The following is a description of a gene set: Human Gene Set: HE_LIM_SUN_FETAL_LUNG_C7_FGFBP2_POS_NEURAL_PROGENITOR_CELL species: Homo sapiens FGFBP2+ Neural progenitor from publication He P, Lim K, Sun D, Pett JP, Jeng Q, Polanski K, Dong Z, Bolt L, Richardson L, Mamanova L, Dabrowska M, Wilbrey-Clark A, Madissoon E, Tuong ZK, Dann E, Suo C, Goh I, Yoshida M, Nikolić MZ, Janes SM, He X, Barker RA, Teichmann SA, Marioni JC, Meyer KB, Rawlins EL (PMID 36493756), and this is the list of marker genes: AQP1, RIMS3, ANKHD1, PSMB8, SCGB3A2, VIP, ADM (NCBI Gene Id 133), VWDE, MIRLET7BHG, RNASE1, CCSER1, MAP3K5, WFIKKN2, ARHGAP18, NKD1, DGKB, TMEM100, WDR27, ERV3-1, NPB, FGFBP2, LAMA5, DDC, PLCD4, EGLN3, FRMD5, NDUFA4L2, DOK4, GRIP2, PLA2G6, VEGFA, MFAP4, BLOC1S5, DNASE2, EGLN2, PLAGL2, SYN2, BCL11A, NFIX, TAPT1, TMT1A, KCNIP4, LINC02268, ZNF599, RAPSN, EPAS1, FRZB, UNC5B, ARHGAP31, SELENOP, SYNM, PKP2